Given this list of marker genes P4HB, CYBA, TXN2, NUDT2, AQP8, PRDX5, GSR, GPX5, PRDX6, TXN, TXNRD1, CCS, NCF2 (neutrophil cytosolic factor 2), CYCS, ATOX1, NOX4, PRDX3, PRDX2, SOD2, PRDX1, GPX7, CYBB, NCF1, GPX2, SOD1, GPX1, TXNRD2, ATP7A, GPX6, SOD3, GPX3, GPX8, NCF4, GSTP1, NOX5, CAT, ERO1A, here is a description of the gene set: Detoxification of Reactive Oxygen Species Human Gene Set: REACTOME_DETOXIFICATION_OF_REACTIVE_OXYGEN_SPECIES studied in species Homo sapiens